The following is a description of a gene set: Any process that controls the length of actin filaments in a cell. Mouse Gene Set: GOBP_REGULATION_OF_ACTIN_FILAMENT_LENGTH species: Mus musculus, and this is the list of marker genes: Vill, Arpc3, Clec2i, Lmod2, Lima1, Naa80, Spta1, Lats1, Ptk2b, Mlst8, Kank3, Dbnl, Grb2, Swap70, Snx9, Svil (supervillin), Cttn, Cracd, Cit, Cyria, Kank1, Tmsb4x, Tmsb15b2, Fmn1, Alox15, Add1, Fchsd1, Shroom2, Baiap2, Myh9, Nphs1, Arpc5 (NCBI Gene Id 67771), Mtpn, Tmsb15l, Brk1, Bbs4, Cdc42ep3, Plek, Myo1c, Sema5a, Rdx, Hax1, Bag4, Hip1r, Ccl21d, Coro1a, Icam1, Capn1, Slit2, Capzb, Tmod2, Pik3r2, Eln, Vil1, Kirrel1, Arfgef1, Dlg1, Actn2, Pfn5, Cfl2, Csf3, Ppp1r9a, Actr3, Twf1, Gsn, Myo3b, Esam, Pak3, Ssh2, Prkcd, Cfl1, Ccl21e, Ssh1, Tpm1, Scin, Arpc5l, Specc1l, Pik3ca, Cyfip2, Pfn2 (profilin 2), Baiap2l2, Ccl11, Pfn3, Rac1, Washc1, Capza2, Tenm1, Nck1, Gba2, Sh3bp1, Was, Cdc42ep2 (CDC42 effector protein 2), Capza3 (NCBI Gene Id 12344), Wdr1, Tmod1, Carmil1, Dstn, Pfn1, Arhgap18, Plekhh2, Dmtn, Kank2, Map3k1, Tmod3, Capza1b, Fer, Rhoa, Cotl1, Arhgap40, Add2, Cyrib, Hcls1, Twf2, Gm14137, Rictor, Prkce, Lmod1, Bin1, Ssh3, Capg, Carmil2, Myo3a, Ccl24, Arhgap35, Abitram, Mkks, Cdc42ep1 (CDC42 effector protein 1), Avil, Prex1, Tlr2, Cdc42ep4, Kank4, Daam2, Mtor, F2rl1, Capza1, Arpc2, Rasa1, Sptan1, Cdc42ep5, Sptb, Neb, Flii, Dbn1, Pycard, Pecam1, Nck2, Fhod3, Pdxp, Tmod4, Baiap2l1, Fchsd2, Myadm, Cyfip1, Arf6, Ccl21b, Lmod3, Eps8, Add3, Sptbn1, Vasp, Ccl21a, Evl, Plekhg2, Arhgap28, Nckap1 (NCBI Gene Id 96983), Ccl21f, Ccl26, Nckap1l